Given this list of marker genes GP1BA, COG1, ABCG8, CD36, ITGA2B, SLC35A1 (NCBI Gene Id 10559), MYH9, ABCG5 (NCBI Gene Id 64240), GP1BB, GALE, LBR, GP9, here is a description of the gene set: species: Homo sapiens Giant platelets are larger than 7 micrometers and usually 10 to 20 micrometers. The term giant platelet is used when the platelet is larger than the size of the average red cell in the field. (Description adapted from College of American Pathologists, Hematology Manual, 1998). Giant platelets Human Gene Set: HP_GIANT_PLATELETS